Given this list of marker genes VIL1, LPAR4, LPAR1, CLN6, PNPLA3, PPT1, TPP1, GAP43, here is a description of the gene set: studied in species Homo sapiens Binding to lysophosphatidic acid (LPA), a phospholipid derivative that acts as a potent mitogen due to its activation of high-affinity G protein-coupled receptors. Human Gene Set: GOMF_LYSOPHOSPHATIDIC_ACID_BINDING